Given this list of marker genes SOD1, TCP1, IL12B, PAK2, STAT4, CNN2, HNRNPA2B1, SNRPA1, IL27RA, JAK1, IL27, P4HB, MIF, JAK2, RALA, RAP1B, IL23A, PITPNA, LCP1, IL12RB2, VAMP7, BOLA2B, IL12RB1, IL6ST, AIP, HNRNPDL, PSME2, GSTA2, ANXA2, EBI3, HNRNPF, IL23R, PPIA, TALDO1, TYK2, CANX, BOLA2, STAT3, CA1, GSTO1, STAT1, CRLF1, SERPINB2, ARF1, IL10, SOD2, RPLP0, CAPZA1, MTAP, LMNB1, IL12A, CDC42, PDCD4, MSN, HSPA9, IFNG, CFL1, here is a description of the gene set: Human Gene Set: REACTOME_INTERLEUKIN_12_FAMILY_SIGNALING species: Homo sapiens Interleukin-12 family signaling